The following is a description of a gene set: Mouse Gene Set: GOBP_PROTEIN_INSERTION_INTO_MITOCHONDRIAL_INNER_MEMBRANE_FROM_MATRIX The process in which a protein is incorporated into the mitochondrial inner membrane from the matrix side. This includes membrane insertion of newly synthesized mitochondrially-encoded proteins, and insertion of nuclear-encoded proteins after their import into the mitochondrial matrix. species: Mus musculus, and this is the list of marker genes: Cox18, Oxa1l, Bcs1l, Tmem126a, Maip1 (NCBI Gene Id 98197)